Given this list of marker genes Lif, Osr1, Lhx1, Cd24a, Ctnnb1, Pax2, Mef2c, Pax8, Wwtr1, Gata3, Prom1, Fat4, Mtss1, Yap1, Stat1, here is a description of the gene set: Mouse Gene Set: GOBP_NEPHRON_TUBULE_EPITHELIAL_CELL_DIFFERENTIATION studied in species Mus musculus The process in which relatively unspecialized cells acquire specialized structural and/or functional features that characterize the cells of the nephron tubule as it progresses from its formation to the mature state.